The following is a description of a gene set: Mouse Gene Set: GOBP_NEGATIVE_REGULATION_OF_SUBSTRATE_ADHESION_DEPENDENT_CELL_SPREADING studied in species Mus musculus Any process that stops, prevents or reduces the frequency, rate or extent of substrate adhesion-dependent cell spreading., and this is the list of marker genes: Meltf, Tacstd2, Postn, Coro1c, Kank1, Actn4, Itgb1bp1, Bcar1, Rcc2, Efna5, Ap1ar, Fbln1, Spry4, Dmtn